Given this list of marker genes NRIP1, DMC1, PTGER2, TSC2, CYP19A1, TSC1, NCOR1, SYNE2, CREB1, LHCGR, FMR1, GJA4, TBP, RAD51, ESR2, SMPD1, MTOR, DAZL, CDK4, FIGLA, ZP3, CEBPB, BMPR1B, SMAD3, CCND2, AKT1, FSHR, PGR, NR5A1, PRLR, MSH5, GDF9, EGR1, CDKN1B, VDR, INHA, ATM, MLH1, ZP2, here is a description of the gene set: Human Gene Set: WP_OVARIAN_INFERTILITY studied in species Homo sapiens Ovarian infertility